The following is a description of a gene set: Human Gene Set: GAVISH_3CA_METAPROGRAM_EPITHELIAL_ANDROGEN_PROSTATE from publication Gavish A, Tyler M, Greenwald AC, Hoefflin R, Simkin D, Tschernichovsky R, Galili Darnell N, Somech E, Barbolin C, Antman T, Kovarsky D, Barrett T, Gonzalez Castro LN, Halder D, Chanoch-Myers R, Laffy J, Mints M, Wider A, Tal R, Spitzer A, Hara T, Raitses-Gurevich M, Stossel C, Golan T, Tirosh A, Suvà ML, Puram SV, Tirosh I (PMID 37258682) In this study, an extensive analysis was conducted to define meta-programs (MPs) capturing intra-tumor heterogeneity across a spectrum of tumor types. The approach utilized non-negative matrix factorization (NMF) to analyze each cell type separately within individual tumor samples. This involved the analysis of malignant cells, macrophages, fibroblasts, endothelial cells, epithelial cells, T-cells, and B-cells. NMF was executed with varying parameter values (K=4, 5, 6, 7, 8, 9), thereby generating 39 programs for each cell type per sample. Each NMF program was summarized by the top genes based on NMF coefficients.\nRobust MPs were then delineated for each cell type using a set of stringent criteria, including recurrence within the same tumor, similarity to programs in other tumors, and non-redundancy within a tumor. Subsequently, these robust NMF programs were clustered (per cell type) based on Jaccard similarity, leading to the identification of MPs associated with each cell type.\nTo enhance the quality of the MPs, a refinement steps were undertaken, involving the removal of MPs suspected of reflecting low-quality data (with an overrepresentation of ribosomal proteins or mitochondrial-encoded genes), single-study inclusion, or similarity to miss-annotated cell types. species: Homo sapiens Genes upregulated in subsets of cells of a given type within various tumors, and this is the list of marker genes: SLC45A3, LAMP2, KLK3, SMS, TRGC1, AGR2 (anterior gradient 2, protein disulphide isomerase family member), GOLM1, SORD, PDLIM5, LRRC26, TSPAN1 (tetraspanin 1), FAM3D, ACP3, CRACR2B, PPP1R1B, AZGP1, CDC42EP5, RDH11, SCGB2A1, NUCB2, ADIRF, WNK4, H2AJ, SLC44A4, KLK11, PLA2G2A, SLC39A6, PPP3CA, CCN3, ELAPOR1, STEAP2, CPE, NPDC1, TFF1, SEC11C, DHRS7, TFF3, PLPP1, TMPRSS2, NKX3-1, TSPAN8, STEAP4, VSIG2, RAMP1, NDRG1, IFI6, SLC12A2, KLK2, MSMB, SPDEF